Given this list of marker genes USP4, RDH16, DNAJA3, PKNOX1, E2F6, MAGED2, LUC7L, TAP1, CHRNB1, ATG14, PRRG2, KLF5, SETDB1, ARID3A, KLHL20, ALLC, DCAF10, UBE2G2, HTR1E, EIF3I, AASS, DUS1L, PTPRR, GLS2, STARD8, HSPB8, GPR88, NUP188, TGFBI, FHOD3 (NCBI Gene Id 80247), ZNF239, TRPC2, BNIP1, KYAT1, POMGNT1, TCHH, PSG2, CST5, DRICH1, FOXL2, DOCK5, GALR1, SCAMP2, KLK10, ULK1, RCE1, TMEM161A, LRRC8E, CERS4, EPHA7, DYNC1I1, ELAVL2, GPR135, UBXN1, SPSB3 (splA/ryanodine receptor domain and SOCS box containing 3), ZNF415, STAT3, ADGRD2, GNL1, IL9R, GABARAP, FAM153A, PTPRH, FUT2, MPO, FCGRT, CEL, GABRP, GCM1, SERPINB5, TRAPPC4, ZNF512B, ZXDB, PHF1, TMEM212, MGAT1, ELF4, TRAPPC14, ARFGAP1, ASB8, NAT9, DHPS, SV2C, ATOX1, WNT10B, WSCD2, SHFL, DCLK1, FMOD, HARS2, PABPN1, FOXD3, GML, FASTK, FABP2, DNASE1L3, ZPR1, SNTA1, IGFBP4, PDE1A, NFE2L2, A4GNT, ALAD, ANP32A, WDTC1, POLG, KRTAP5-9, JAK1, SLC15A3, PMP22, MEN1, HAND2, CTPS2, MNS1, TMEM127, HLA-F, ATP7B, EFNB1, CROCCP3, TSR2, BSN, ALDH6A1 (NCBI Gene Id 4329), SNU13, PSMD7, ZNF324, ARHGEF10L, TOM1, HTR3B, AGT, DPP8, AP1G1, TM6SF2, MYF6, ITGB8, CLEC4M, RNF4, NXF1, RETREG2, BAG6, GLP1R (glucagon like peptide 1 receptor), ABT1, LGI1, RPS23, NOP2, R3HDM4, INPP5K, RBM23, TEC, NUDT7, LRP12, GID4, TIMM44, BRD9, TFPI2, ATP1B3, CCDC92, INSRR, SELPLG, NPRL2, PSKH1, CORO7, IGFBP7, SAP30L, KCTD3, COL4A3, BCAT2 (NCBI Gene Id 587), OR1F1, C2, HIGD1B, POLR2H, BCS1L, ATP8B2, TMEM104 (NCBI Gene Id 54868), POGK, NRIP3, CAPZA1, CYP11B1, DAXX, RANGRF, POLR1D, FRMPD4, GON4L, BRD4, NDUFC1, SGSH, MAU2, AMELY, SLC7A9, LRTM1, PHKA2, NTM, STC1, NR1H3, ABCA1, ZBP1, GTF3C2, KLK3, MVP, here is a description of the gene set: studied in species Homo sapiens from publication Wirth TC, Xue HH, Rai D, Sabel JT, Bair T, Harty JT, Badovinac VP (PMID 20619696) Genes down-regulated in 1'Memory CD8T versus 2'Memory CD8T. The transcriptome of naive OT-I T cells was compared to memory CD8 T cells after 1, 2, 3, or 4 infection with ovalbumin expressing Listeria monocytogenes (LM-OVA). Human Gene Set: GSE21360_PRIMARY_VS_SECONDARY_MEMORY_CD8_TCELL_DN